Given this list of marker genes Psma3, Psmc6, Sel1l, Notum, Psmb4, Psma1, Psmd7, Psmd6, Psma6, Psma2, Rps27a, Psmb6, Psmc4, Vcp (valosin containing protein), P4hb, Psmc3, Psmd13, Psmc5, Psma7, Hhat (NCBI Gene Id 226861), Psmd1, Psmb7, Psma4, Ihh, Shh, Psmd12, Psmc2 (NCBI Gene Id 19181), Ubb, Erlec1, Psmb5, Psma5, Psmc1, here is a description of the gene set: This event has been computationally inferred from an event that has been demonstrated in another species.<p>The inference is based on the homology mapping from PANTHER. Briefly, reactions for which all involved PhysicalEntities (in input, output and catalyst) have a mapped orthologue/paralogue (for complexes at least 75% of components must have a mapping) are inferred to the other species. studied in species Mus musculus electronically inferred by orthology from the curated human pathway part of: Signaling by Hedgehog Reactome Pathway: Hedgehog ligand biogenesis